The following is a description of a gene set: species: Mus musculus Binding to a protein upon acetylation of the target protein. Mouse Gene Set: GOMF_ACETYLATION_DEPENDENT_PROTEIN_BINDING, and this is the list of marker genes: Pou5f1, Brdt, Trim24, Zmynd8, Ep300, Thap7, Zzz3 (zinc finger, ZZ domain containing 3), Atad2b, Mllt3, Phip, Taf1, Smarca4, Sirt1, Mllt1, Brd3, Brd7, Zzef1, Brd4, Baz2a, Dpf2, Kmt2a, Stat3, Carm1, Yeats4, Brd9, Psme4, Nanog, Brd2 (bromodomain containing 2)